The following is a description of a gene set: Mouse Gene Set: GOBP_POSITIVE_REGULATION_OF_ACTIN_FILAMENT_POLYMERIZATION Any process that activates or increases the frequency, rate or extent of actin polymerization. studied in species Mus musculus, and this is the list of marker genes: Map3k1, Gm14137, Alox15, Baiap2l2, Fchsd2, Snx9, Fchsd1, Ccl21b, Ccl24, Kirrel1, Pycard, Cdc42ep1, Ccl21a, Mtor, Nckap1 (NCK-associated protein 1), Cdc42ep3, Rhoa, Cttn, Myo1c, Arf6, Cdc42ep4, Arpc2, Prkce (protein kinase C, epsilon), Pfn1, Ptk2b, Grb2, Evl, Nphs1, Ccl21f, Dlg1, Cdc42ep5, Fer, Pfn2, Bag4, Nck1, Csf3, Baiap2, Rictor, Rac1, Vasp, Tenm1 (NCBI Gene Id 630184), Carmil1, Ccl21e, Nckap1l, Mlst8, Bin1, Lmod1, Cdc42ep2, Carmil2, Ccl11, Ccl26, Ccl21d, Nck2, Actr3, Icam1, Baiap2l1, Cracd, Lmod2, Fmn1